The following is a description of a gene set: Mouse Gene Set: GOBP_LYMPH_VESSEL_DEVELOPMENT The process whose specific outcome is the progression of a lymph vessel over time, from its formation to the mature structure. species: Mus musculus, and this is the list of marker genes: Nfatc1, Pkd1, Npr2 (natriuretic peptide receptor 2), Vegfc, Ptpn20, Ccbe1, Ngp, Tie1, Svep1, Prox1, Syk, Vash1, Pdpn, Heg1, Tbx1, Fgf2, Flt4, Foxc2, Tmem204, Clec14a, Ppp3cb, Epha2, Ptpn14 (NCBI Gene Id 226829), Acvr2b, Kdr, Bmpr2, Sox18, Lgals8, Vegfa, Foxc1, Nr2f2, Acvrl1, Efnb2